The following is a description of a gene set: part of: Transcriptional regulation by RUNX3 studied in species Homo sapiens RUNX3 negatively regulates NOTCH signaling, which contributes to the tumor suppressor role of RUNX3 in hepatocellular carcinoma. RUNX3 binds the promoter of the JAG1 gene, encoding NOTCH ligand JAG1 and inhibits its transcription. In addition, RUNX3 also binds to the NOTCH1 coactivator complex at the promoter of HES1, a NOTCH target gene, and inhibits HES1 transcription. Reactome Pathway: RUNX3 regulates NOTCH signaling, and this is the list of marker genes: HES1, EP300, KAT2B, JAG1, MAML2, KAT2A, MAML1, RUNX3, MAMLD1, SNW1, NOTCH1, RBPJ, CREBBP, MAML3